The following is a description of a gene set: studied in species Mus musculus Combining with an MHC class I protein complex to initiate a change in cellular activity. Class I here refers to classical class I molecules. Mouse Gene Set: GOMF_MHC_CLASS_I_RECEPTOR_ACTIVITY, and this is the list of marker genes: Lilra6, Cd160, Pira2, Lilra5, Pira13, Pira12, Ctsh, Mfsd6, Pirb